The following is a description of a gene set: species: Homo sapiens Human Gene Set: GOCC_9PLUS2_MOTILE_CILIUM A motile cilium where the axoneme has a ring of nine outer microtubule doublets plus two central microtubules (and is therefore called a 9+2 axoneme)., and this is the list of marker genes: USP26, DNAH3, ADGB, ODF2, DUSP21, CFAP43, NEK5, CFAP53, DRD2, CFAP119, HSPD1, CFAP65, DNAI2, MROH2B, DRC1, PGK2, CCDC181, OAZ3, CFAP126, CALM1, RHO, SAXO1, TSSK3, SPMIP8, CST11, PTCHD3, NME5 (NCBI Gene Id 8382), IRGC, CATSPERB, DNAH11, TACR2, CFAP210, SPAG16, DYNC2H1, IFT172, SPACA3, DNALI1, TCP11X2, SPACA5, TEKT3, SLC26A3, PRKACA, ATP1B1, GAS8, ATP2B4, IQCG, SLC26A6, CCDC34, CFAP144, LRRC46, CETN2, RSPH6A, AK2, CIMIP4, SPATA3, CFAP221, TSGA10, RIBC2, SLC9B2, AKAP3, HSP90AA1, SEPTIN2, SLC9B1, RSPH1, EFCAB6, TEKT5, PMFBP1, DCDC2C, TCTE1, SLC22A14, CFAP61, DEFB1, CFAP45, HYDIN, EFHC1, IFT88, SEPTIN6, ODAD3, CCDC146, IL4I1, CCDC42, KIF9, DYNLT4, DNAJB13, DNAH1, SPMIP6, PPP3R2, CCDC172, HYAL3, DNAI1, C2CD6, CBY1, SPAG6, SPMIP9, SPAG8, TMEM249, CROCC, DNAH14, CFAP107, SCNN1A, CFAP74, C11orf42, SAXO4, PIERCE1, SEPTIN4, ATP1B3, FSIP2, TEKT1, KCNU1, TEX55, TEKT4, HVCN1, CFAP69, DNAH2, CATSPER4, CD52, SAXO2, CABCOCO1, CFAP251, CBY3, CIBAR1, DNHD1, SPACA9, LRRC23, GK2, CTSH, SPATA33 (spermatogenesis associated 33), CFAP95, CFAP20, RNF38, WBP2NL, SPMIP11, TTLL8, ATP1A4, AK8, TPPP2, RSPH3, CLXN, MNS1, CFAP90, CATSPERE, TSSK6 (testis specific serine kinase 6), QRICH2, TTC29 (tetratricopeptide repeat domain 29), FSCB, ZMYND12, DNAH17, RIBC1 (NCBI Gene Id 158787), AKAP4, DNAH7, VPS13A, DNAH5, SQSTM1, ATG16L1, CIMIP2C, CALM3, CFAP70 (NCBI Gene Id 118491), VDAC2, RAN, TACR3, TOMM20, AK1, ODF1, ENKUR, LDHA, DNAH10, SPA17, TLE6, CFAP276, TEKTIP1, LYZL4, SLC26A8, CABS1, TACR1, NME7, TCP11, PFKM, SSX1, NME8 (NCBI Gene Id 51314), TEKTL1, TSSK4, DRC3, DNAH9, CCDC38, RPGR (NCBI Gene Id 6110), TMEM232, CFAP77, FHAD1, RSPH10B2, IFT27 (NCBI Gene Id 11020), EFHC2, CATSPER1, DDX6, CFAP57, NHERF1, CFAP161, PCDH11Y, CIMIP2A, CFAP141, PIERCE2, EFCAB2, CUL3, PACRG, GABARAP, ODAD4, TCP11X1, TUBA1A, RAP1A, EFHB, IQUB, GSTM3, SPEF1, PGAM4, CATSPERD, CIMAP1A, ABHD2, CATSPERG, EFCAB9, BBOF1, CALM2, GARIN2, DNAH6, DNAH8, RSPH4A, CFAP68, MORN5, SPMIP10, LYZL6, ATP1A1, TUBB4B, CCR6, RSPH10B, TEKT2, SEPTIN12, CFAP52, CATSPERZ, CFAP58, CABYR, SPATA19, SPACA5B, IFT81, TTLL3, SEPTIN7, FLACC1, SLIRP, TBC1D21, SPEF2, RSPH9, CT55